Given this list of marker genes Hnf1b, Bax, Tgfbr3, Pml, Foxc1, Notch1, Cdkn2a, Tnfrsf1b, Tnfrsf1a, Vdr, Wt1, Bmp7, Pax8, Pax2, Tgfb2, Foxc2, here is a description of the gene set: studied in species Mus musculus Any process that modulates the frequency, rate or extent of apoptotic process involved in development. Mouse Gene Set: GOBP_REGULATION_OF_APOPTOTIC_PROCESS_INVOLVED_IN_DEVELOPMENT